Given this list of marker genes PRKAA1, CSNK2A2, USP36, ATG13, VPS11, PINK1, UBL4B, NMT1, TOMM7, HTRA2, BBC3, HSPA1L, NPEPPS, SH3GLB1, RHOU, MAPK8, GSK3A, MICALL2, HUWE1, UBL5, UBE2D3, RAC2, HPS4, TOMM70, RNF31, LEPROT, UBE2J2, GZMB, UBE2L3, ABLIM3, BAP1, ADCY10, FZD5, FBXW7, SREBF2, SAE1, ARIH2, here is a description of the gene set: Any process that activates or increases the frequency, rate or extent of establishment of protein localization to mitochondrion. species: Homo sapiens Human Gene Set: GOBP_POSITIVE_REGULATION_OF_ESTABLISHMENT_OF_PROTEIN_LOCALIZATION_TO_MITOCHONDRION